Given this list of marker genes MOAP1, ZC2HC1C, CBX4, GABPA (GA binding protein transcription factor subunit alpha), RTL10, NR3C1, RDH8, SLC7A5, NKX6-1, ZNF674, FLT1, DNTTIP2, MAPK8, SOCS3, TOPORS, ITCH, HOXB9, MYF5, FBLN5, ENOSF1, PLAC8, MAGEA5P, IL1RN, NRIP3 (NCBI Gene Id 56675), SLC3A2, TAF4, STX4, RAPGEF6, ARF6, ATP6V0A4, AIM2, PRKRA, SUPT6H, CHRNA10, ARHGEF7, PYGB, TSPYL1, ST3GAL6, PIK3C3, RABGGTB, JUNB, SH2B3, TAF7, MACO1, ASH1L, PRKCD, GALNT12, CORO1C, PPP1R15A, SFT2D2, TCTN1, DLEU2, KHDC1L, ZNF365, RAB7A, RAB1A, EIF2AK3, BDKRB2, ARF4, NPY5R, CNIH4, INSIG1, SOX13, CTRC (NCBI Gene Id 11330), SORBS2, KRT83, TSPAN31, IER2, TMEM39A, SFPQ, HUNK, KRT8P12, LRRC8E, PFKFB3, DCP1A, MAGEA12, RAB22A (NCBI Gene Id 57403), LUC7L, AGFG1, TRBC1, CHPF2, TAB2, HMG20B, SNAPC2, GULP1, CDV3, UBE2D3 (ubiquitin conjugating enzyme E2 D3), NPIPB15, RHOBTB3, IRF4, HUS1, EIF6, NCS1, ANXA5, TFEB, CHMP1B, ASCC1 (NCBI Gene Id 51008), FKBP1B, PDLIM3, HBB, BCL2L11, NUP88, WHRN, AMMECR1, EPS8L1, ZNF143, TASOR2, LARP4B, KDM6B, NKAIN1, TMC6, RGS1, TNFSF14, SDC3, G3BP2, RGS17, CHSY1, IL6, ATF1, MICALL2, USP7 (ubiquitin specific peptidase 7), ELP5, CTF1, RCN1, MAP3K19 (mitogen-activated protein kinase kinase kinase 19), MED17, CDH17, SELENOF, MAP2K3, PPP1CB, CMKLR1, FBXO28, CD82, RRP15, RBM48, TBR1, SEMA6A, TNS4, PPME1, KIF25, KDM5C, ERF, ICAM5, SGMS1, RNF10, MAMLD1, AZI2, MYH7B, BTG3, PCBP3, HS2ST1 (NCBI Gene Id 9653), CEP170B, EPHA7, TNFRSF1B, MPPED1, H2BC4, ACTR10, RPL23AP53, LIG3, SOCS1, KPNA2, DONSON, TNFRSF1A, RHEB, GPRC5A, ANK1, SKI, LPIN1, UPK1A, OSGIN1, DLG4, FCGR2C, RBM3, HGS, ENTPD7, CSTA, ZNF274, DDX21, TIMP1, PRDM2, TMEM87A, NXF1, KRT14, ZNF335, AUTS2, DNAH17, PHF14, TTC4, PLA2G4C, STK38L, MAP3K14, FBXO11, RANBP2, LRRFIP2, PPFIBP1, SRSF5, EIF4E, COPB1, here is a description of the gene set: Human Gene Set: GSE20152_SPHK1_KO_VS_WT_HTNFA_OVERXPRESS_ANKLE_UP from publication Baker DA, Barth J, Chang R, Obeid LM, Gilkeson GS (PMID 20644167) species: Homo sapiens Genes up-regulated in ankle joints over-expressing TNF: SPHK1 knockout versus wildtype. The study analyzes analyzes gene expression changes in the ankle joint in mouse TNFa overexpression models with or without sphingosine kinase 1 activity. SphK1 is a sphingolipid enzyme that converts sphingosine to bioactive sphingosine-1-phosphate (S1P). Recent data suggest a potential relationship between SphK1 and TNFα and have implicated SphK1/S1P in the development and progression of inflammation. Here we further study the relationship of TNFα and SphK1 using an in vivo model. Transgenic hTNFα mice, which develop a spontaneous arthritis (limited to paws) at 20 weeks, were crossed with SphK1 activity null mice (SphK1-/-) to study the development of inflammatory arthritis in the functional absence of SphK1. Results show that hTNF/SphK1-/- have significantly less severity and progression of arthritis and bone erosions as measured through micro-CT images. Additionally, less COX-2 protein, mTNFα transcript levels and fewer Th 17 cells were detected in the joints of hTNF/SphK1-/- compared to hTNF/SphK1+/+ mice. Microarray analysis of the ankle joint showed that hTNF/SphK1-/- mice have increased transcript levels of IL-6 and SOCS3 compared to hTNF/SphK1+/+ mice. Finally, fewer mature osteoclasts were detected in the ankle joints of hTNF/SphK1-/- mice compared to hTNF/SphK1+/+ mice. These data show that SphK1 plays a role in hTNFα induced inflammatory arthritis, potentially through a novel pathway involving IL-6 and SOCS3.